The following is a description of a gene set: studied in species Homo sapiens Bone-marrow foam cells The presence of foam cells in the bone marrow, generally demonstrated by bone-marrow aspiration or biopsy. Foam cells have a vacuolated appearance due to the presence of complex lipid deposits, giving them a foamy or soap-suds appearance. Human Gene Set: HP_BONE_MARROW_FOAM_CELLS, and this is the list of marker genes: NPC1, NPC2, LIPA, SMPD1, NEU1 (neuraminidase 1)